Given this list of marker genes Itga2b, Fgfr1, Itga5, Map2k2, Csnk2b, Mapk3, Egfr, Map2k1, Ncam1, here is a description of the gene set: This event has been computationally inferred from an event that has been demonstrated in another species.<p>The inference is based on the homology mapping from PANTHER. Briefly, reactions for which all involved PhysicalEntities (in input, output and catalyst) have a mapped orthologue/paralogue (for complexes at least 75% of components must have a mapping) are inferred to the other species. part of: L1CAM interactions electronically inferred by orthology from the curated human pathway Reactome Pathway: Signal transduction by L1 species: Mus musculus